The following is a description of a gene set: The class C G-protein-coupled receptors are a class of G-protein coupled receptors that include the metabotropic glutamate receptors and several additional receptors (Brauner-Osborne H et al, 2007). Family C GPCRs have a large extracellular N-terminus which binds the orthosteric (endogenous) ligand. The shape of this domain is often likened to a clam. Several allosteric ligands to these receptors have been identified and these bind within the seven transmembrane region. Reactome Pathway: Class C/3 (Metabotropic glutamate/pheromone receptors) part of: GPCR ligand binding studied in species Homo sapiens, and this is the list of marker genes: TAS2R14, CASR, GRM4, GRM6, TAS2R46, TAS2R19, TAS2R16, GRM5 (glutamate metabotropic receptor 5), GABBR2, TAS1R1, TAS2R43, TAS2R10, TAS2R3, GRM2, GPRC6A, TAS2R39, TAS2R31, GRM3, TAS2R4, TAS2R41, TAS2R45, TAS2R8, TAS2R60, GRM7, GRM1, TAS1R2, GRM8, TAS2R30, TAS2R5, TAS2R40, TAS2R7, TAS2R50, TAS2R20, TAS2R38, TAS2R1 (taste 2 receptor member 1), TAS2R42, GABBR1, TAS2R9, TAS2R13, TAS1R3